Given this list of marker genes Hspa1b, Hspa8, Hspa1a, Pink1, Dnaja1, Kcnh2, here is a description of the gene set: Binding to a C3HC4-type zinc finger domain of a protein. The C3HC4-type zinc finger is a variant of RING finger, is a cysteine-rich domain of 40 to 60 residues that coordinates two zinc ions, and has the consensus sequence: C-X2-C-X(9-39)-C-X(1-3)-H-X(2-3)-C-X2-C-X(4-48)-C-X2-C, where X is any amino acid. Many proteins containing a C3HC4-type RING finger play a key role in the ubiquitination pathway. Mouse Gene Set: GOMF_C3HC4_TYPE_RING_FINGER_DOMAIN_BINDING species: Mus musculus